The following is a description of a gene set: The process in which antigen-activated dendritic cells acquire the specialized features of a mature conventional dendritic cell. Mature conventional dendritic cells upregulate the surface expression of MHC molecules, chemokine receptors and adhesion molecules, and increase the number of dendrites (cytoplasmic protrusions) in preparation for migration to lymphoid organs where they present antigen to T cells. studied in species Homo sapiens Human Gene Set: GOBP_MATURE_CONVENTIONAL_DENDRITIC_CELL_DIFFERENTIATION, and this is the list of marker genes: LGALS9, PRTN3, CCR7, TAOK3, F2RL1, CCL19